The following is a description of a gene set: from publication Di Martino JS, Nobre AR, Mondal C, Taha I, Farias EF, Fertig EJ, Naba A, Aguirre-Ghiso JA, Bravo-Cordero JJ (PMID 35121989) Human Gene Set: DI_MARTINO_MATRISOME_HIGHLY_PROLIFERATIVE_HNSCC_TUMOR_CELL_DERIVED Tumor-cell-derived matrisome proteins detected exclusively in highly proliferative head-and-neck squamous cell carcinoma human-to-mouse xenografts (T-Hep3) compared to dormant head-and-neck squamous cell carcinoma human-to-mouse xenografts (D-Hep3). studied in species Homo sapiens By using ECM proteomics we have defined the matrisome of dormant cancer cells vs proliferative cancer cells of head and neck squamous cell carcinoma (HNSCC). To do so, we used established cellular dormancy models and their proliferative counterparts: proliferative (T-HEp3) and dormant (D-HEp3) HNSCC. To investigate the matrisome composition of these dormant and proliferative tumors, we performed ECM-enriched mass spectrometry using decellularized T-HEp3 tumors and D-HEp3 dormant nodules grown in mice. Analysis of indolent D-HEp3 dormant nodules and aggressive T-HEp3 tumors grown in mice show a significant dysregulation of the matrisome signature. The human-in-mouse xenograft system used further allowed us to determine the relative contribution of tumor cells (human peptide sequences) and stromal cells (murine peptide sequences) to the production of the matrisome. This gene set lists the tumor-derived matrisome proteins detected exclusively in highly proliferative HNSCC human-to-mouse xenograft compared to dormant HNSCC human-to-mouse xenograft. We further excluded proteins that were detected in only one of the three proliferative samples., and this is the list of marker genes: EMILIN1, LTBP1, ANXA2, S100A6, COL4A2, COL16A1, LGALS1, TNC, FN1, COL12A1, FBN2 (NCBI Gene Id 877), ITIH2, TGFBI, COL6A2, COL7A1, TGFB1, POSTN